Given this list of marker genes PCMTD1, ZHX2, MAP4K3, SEMA4F, ACOT2, NDNF, AMPD3, HSD17B11, APP, CLYBL, DNAJB2, TMEM109, ST8SIA4, PTCD3, TBXA2R, CNTFR, PRSS12, LYPD6B, SETD6, ZC3H8, MAP2K6, EARS2, FNDC10, UNC5CL, RHOBTB2, STK38, SCML4, SSC5D, IMPACT, MTURN, BTG2, ACVR1B, PFKFB2, QPCT, ST8SIA6, PLEKHM2, DNAJC28, JMJD1C, CBX7, JMY, ATN1, BMP1, FOXO3, DNAJB14, EPAS1, IL7R (interleukin 7 receptor), IFT140, PXYLP1, CDR2, ZNF764, EID2, PUM3, RESF1, MBP, ZSWIM5, GAB3, CYTH3, EYA2, CCDC85B, TRMT10C, PROS1, RPS15A, LIG3, SNAI3, ICOSLG, MAST3, SGK1, LYST, B4GALT1, ZNF606, CCR7, CACNA2D4, GLIPR1, HSD11B1, DTX4, ZC3H6, TLE1, ZNF652, EEF1G, SPDEF, WDR43, DIPK1A, TMEM209, UST, MYO9A, GTPBP6, ATP10D, CARD6, KBTBD2, RNF167, TXNIP, RPS11, RPL3, ST3GAL6, GBE1, RPF2, PDE8A, DMRTA1, FAM120B, MGAT4A, FEZ2, TRMT9B (tRNA methyltransferase 9B (putative)), OGFOD3, CWF19L1, SGMS1 (NCBI Gene Id 93538), PADI2, PAXX, ID2, NEDD4L (NEDD4 like E3 ubiquitin protein ligase), IL4R, CD2AP, KLF2, ZBTB4, LRATD2 (LRAT domain containing 2), NMNAT2 (NCBI Gene Id 23057), KIAA0930, RPS4X, MAP3K3, VCL, SNHG17, ALS2CL, GPR65, ARL13B, LETM2, EEF1B2, IRF1, EXOSC1, SSBP2, PARP16, TAB2, SHPK, KLF6, LYSMD2, FAM219B, FAM114A2, MYBBP1A (NCBI Gene Id 10514), PPRC1, IER3, ARL4C, RO60, SUCO (NCBI Gene Id 51430), TCP11L2, POLR2E, SERPINA5, ARMC7, CRY1, MPND, UTP20, REXO1 (NCBI Gene Id 57455), MARVELD1, PRPF6, SGF29, PBLD, SERINC1, TRMT13 (tRNA methyltransferase 13 homolog), TSC22D3, CLCF1, SMARCA2 (NCBI Gene Id 95083), CAMK2N1, FOXP1, KIDINS220, TENT5A, KLHL8 (NCBI Gene Id 57563), ALKBH1, CYP2S1, TMEM71, PHC3, ARHGAP15, CHIC1, LDLR, IL27RA, CYP4V2, ATG12, PAG1, CRYBG3, LAIR1, CREB3, RNF141, TRIM44, RPL5, RPS3A, UBQLN2, SERINC4, KCTD6, HSDL1, RARG, RAB20, NDUFA5, PHF21A, DDX5, PIK3IP1, LFNG, CREBL2, DNAJC15, PTPRK, PPM1K, ABHD14A (NCBI Gene Id 25864), PIK3R5, RIOX1, here is a description of the gene set: Human Gene Set: GSE39110_DAY3_VS_DAY6_POST_IMMUNIZATION_CD8_TCELL_WITH_IL2_TREATMENT_DN studied in species Homo sapiens Genes down-regulated in CD8 T cells after immunization: day 3 versus day 6 and IL2 treatment. Much is known concerning the cellular and molecular basis for CD8+ T memory immune responses. Nevertheless, conditions that selectively support memory generation have remained elusive. Here we show that an immunization regimen that delivers TCR signals through a defined antigenic peptide, inflammatory signals through LPS, and growth and differentiation signals through the IL-2R initially favors antigen-specific CD8+ T cells to rapidly and substantially develop into tissue-residing T effector-memory cells by TCR transgenic OVA-specific OT-I CD8+ T cells. Amplified CD8+ T memory development depends upon a critical frequency of antigen-specific T cells and direct responsiveness to IL-2. A homologous prime-boost immunization protocol with transiently enhanced IL-2R signaling in normal mice led to persistent polyclonal antigen-specific CD8+ T cells that supported protective immunity to Listeria monocytogenes. These results identify a general approach for amplified T memory development that may be useful to optimize vaccines aimed at generating robust cell-mediated immunity. Gene expression analysis was performed for OT-I T cells on day 3 and day 5 after activation with ovalbumin and LPS in vivo with and without treatment with IL-2 using an agonists IL-2/anti-IL-2 complexes (IL2/Jes-6.1) from publication Castro I, Dee MJ, Malek TR (PMID 23018461)